The following is a description of a gene set: An abnormality of the prostate. Human Gene Set: HP_ABNORMAL_PROSTATE_MORPHOLOGY studied in species Homo sapiens Abnormal prostate morphology, and this is the list of marker genes: MDM2, GREM1, ZFHX3, HLA-DPA1, NAB2, RAD51, BRCA1, FOXE1, RAD51D, BRCA2, PALB2, PHF6, BMPR1A, COL14A1, AAGAB, MRE11, KLF6, RAD50, MAD1L1, TP53, NTHL1, BRIP1, RNASEL, RNF43, MXI1, CDKN2A, HLA-DPB1, NBN, BARD1 (NCBI Gene Id 580), RAD51C, CTLA4, PRTN3, EPHB2, AR, HGD, BTK, PTEN, PTPN22, CHEK2, STAT6, APC